Given this list of marker genes Tbx21, Slamf6, Btnl1, Lgals1, Mink1 (NCBI Gene Id 50932), Atg5, Gata3, Spn, Fas, Opa1, Cd69, Shh, Il4, Ptprc, Cd74, Srf, Btnl6, Itpkb, Jag2, Brd2, Il23a, Cd3e, Themis, Cd3d, Ccr7 (C-C motif chemokine receptor 7), Card11 (caspase recruitment domain family, member 11), Tgfb1, Rhoa, Mtor (mechanistic target of rapamycin kinase), Gli3, Tox, Cd28, Stat6, Cd3g, Cyld (CYLD lysine 63 deubiquitinase), Nfatc3, Cd4, Brd4, Foxp3, Braf, Loxl3, Bcl11b, Syk, Batf, Il6ra, Zap70, Il15, Cd1d1, Ep300, Ly9, Aire, Irf4, Ptpn2, Foxn1, Bcl2, H2-DMa, Dock2, Otud5, Il6, Stk11, Stat3, Skint1, Ctsl, Tnfsf18, here is a description of the gene set: Mouse Gene Set: GOBP_T_CELL_SELECTION species: Mus musculus The process in which T cells that express T cell receptors that are restricted by self MHC protein complexes and tolerant to self antigens are selected for further maturation.